Given this list of marker genes Nos3, Ctnnb1, Dnm2, Atp2b4, Calm1, Scn5a, Calm2, Dmd, Nos2, Cav1, Snta1, Calm3, Nos1ap, Dnm3, Dnm1, Cdh2, Actb, Slc6a4, Camk2d, Cav3, Cd74, Arg2, here is a description of the gene set: Binding to nitric-oxide synthase. species: Mus musculus Mouse Gene Set: GOMF_NITRIC_OXIDE_SYNTHASE_BINDING